Given this list of marker genes MIA, S1PR2, FGD4, MEF2C, MBP, SEC11C, DNMT1, NANS, FAHD2A, PLEKHF2, RIPK2, P2RX7, CA14, BCAN, FEN1, NHSL1, MRPL35, RAPGEF2, CSRP2, GAS7, PRKCZ, ST3GAL6 (ST3 beta-galactoside alpha-2,3-sialyltransferase 6), LINC00511, TNFRSF19, LMNA, WDR82, KANK1, ABR, LRATD2, ADD3, OSBPL10, H1-9P (NCBI Gene Id 373861), TEX41, DUSP22, INCENP, ATM, GAS2L3, CHN2, ADGRG6, FYN, MYO9B, SDHC (succinate dehydrogenase complex subunit C), ACSS1, HIPK2 (homeodomain interacting protein kinase 2), SASH1, RNF144B, ARHGAP31 (Rho GTPase activating protein 31), OSBPL1A, CDH19, TRIM2, FEM1B, USP6NL, MTURN, TECR, NFIB, SCML4, TTLL4, ERBB3, PTPRJ, OPHN1, RHOJ, DAB2, BBS5, VPS37B, INPP4B, RP9 (NCBI Gene Id 6100), RPE, SEPTIN9, TBC1D16, TRAF3IP2, LINC03048, FSBP, CNPY2, ECHDC1, ST6GAL1, OTUD7B, ZNF697 (NCBI Gene Id 90874), PPP2R2A, MCC (NCBI Gene Id 4163), CHAMP1, ZNF704, ATP11A, ELF1, TBXAS1, ETS1, ANXA5, GLYCTK, SAMMSON, NES, NPAT, MIR3142HG, DIP2B, here is a description of the gene set: studied in species Homo sapiens SOX10 is a transcription factor involved with neural crest development and is expressed in cutaneous melanoma. Loss of SOX10 in cutaneous melanoma has been linked to an invasive phenotype as well as resistance to MAPK targeted therapies. Transcriptomic changes due to SOX10 loss was modeled using RNA-seq data from CRISPR knockout in A375 and MeWo melanoma cell lines. Signature genes were generated from the intersect of ChIP-seq target genes and significantly (BHFDR < 0.05) down-regulated genes. from publication Purwin TJ, Caksa S, Sacan A, Capparelli C, Aplin AE (PMID 37636077) Human Gene Set: PURWIN_MEWO_SOX10_TARGETS Genes with a SOX10 ChIP-seq peak in the promoter region that are commonly down-regulated (BHFDR < 0.05) in two MeWo CRISPR SOX10 knockout clones.